The following is a description of a gene set: part of: tRNA Aminoacylation species: Homo sapiens Reactome Pathway: Mitochondrial tRNA aminoacylation Mitochondrial tRNA synthetases act in the mitochondrial matrix to catalyze the reactions of tRNAs encoded in the mitochondrial genome, their cognate amino acids, and ATP to form aminoacyl-tRNAs, AMP, and pyrophosphate. The synthetase enzymes that catalyze these reactions are all encoded in the nuclear genome. In three cases, glycine, lysine, and glutamine, a single gene encodes two enzyme isoforms, one cytosolic and one mitochondrial. All other mitochondrial tRNA synthetases are encoded by genes different from the ones encoding the corresponding cytosolic enzymes., and this is the list of marker genes: LARS2, NARS2, AARS2, GARS1, EARS2, HARS2, QARS1, VARS2, YARS2, SARS2, KARS1, RARS2, PPA2, PARS2, CARS2, MARS2, WARS2, IARS2, FARS2, DARS2, TARS2